The following is a description of a gene set: Human Gene Set: KEGG_MEDICUS_VARIANT_DELETED_DMD_TO_DYSTROPHIN_ASSOCIATED_PROTEIN_COMPLEX studied in species Homo sapiens Pathway Definition from KEGG: (DAG1+(SNTA1,SNTB1,SNTB2,SNTG1,SNTG2)+DTNA) // DMD* // (ACTB,ACTG1) Deleted DMD to dystrophin-associated protein complex. Pathway ID: N00465. Pathway type: Variant. Pathway class:., and this is the list of marker genes: SNTG2, DMD, SNTB1, DTNA, SNTB2, ACTG1, SNTG1, SNTA1, ACTB, DAG1